The following is a description of a gene set: The live vaccine strain (LVS) of Francisella tularensis is the only vaccine against tularemia available for humans, yet its mechanism of protection remains unclear. We probed human immunological responses to LVS vaccination with transcriptome analysis using PBMC samples from volunteers at time points pre- and post-vaccination. Gene modulation was highly uniform across all time points, implying commonality of vaccine responses. Principal components analysis revealed three highly distinct principal groupings: pre-vaccination (-144 h), early (+18 and +48 h), and late post-vaccination (+192 and +336 h). The most significant changes in gene expression occurred at early post-vaccination time points (<=48h), specifically in the induction of pro-inflammatory and innate immunity-related genes. Evidence supporting modulation of innate effector function, specifically antigen processing and presentation by dendritic cells, was especially apparent. Our data indicate that the LVS strain of F. tularensis invokes a strong early response upon vaccination. This pattern of gene regulation may provide insightful information regarding both vaccine efficacy and immunopathogenesis that may provide insight into infection with virulent strains of F. tularensis. Additionally, we obtained valuable information that should prove useful in evaluation of vaccine lots as well as efficacy testing of new anti-F. tularensis vaccines. Genes down-regulated in peripheral blood mononuclear cell 336h vs 0h in adults (22-54) after exposure to F. tularensis vaccine LVS, time point 336H studied in species Homo sapiens from publication Fuller CL, Brittingham KC, Porter MW, Hepburn MJ, Petitt PL, Pittman PR, Bavari S (PMID 17349694) Human Gene Set: FULLER_PBMC_F_TULARENSIS_VACCINE_LVS_AGE_22_54YO_336HR_DN, and this is the list of marker genes: SOD2, CCR3, TICAM1, FCGR2B, CD80, CD68, CCL18, CD83, IRAK1, CCL20, CCR6, CCL19, HSP90B1, CD58, CD1A, B2M, IRAK1BP1, PYCARD, CD1B, TAP2, CCL16, ICAM1, CARD14, CCR7, CCL22, CD44, CD209, CD74, ICOS, LAMP3, DCSTAMP, CD81